Given this list of marker genes ATP1A2, TREX1, GAL, SCN1A, PI4KA, NHLRC1 (NHL repeat containing E3 ubiquitin protein ligase 1), LGI1 (NCBI Gene Id 9211), SRPX2, CACNA1A, NPRL2, KCNA1, EPM2A, MICAL1, PDE2A, DEPDC5, PCDH19 (protocadherin 19), RELN, PRRT2, ADGRG1, NPRL3, CNTN2, SCN8A, here is a description of the gene set: Epileptic aura Human Gene Set: HP_EPILEPTIC_AURA studied in species Homo sapiens An epileptic aura is a purely subjective clinical manifestation of an epileptic seizure. If an epileptic aura is not followed by loss of awareness or propagation to a bilateral tonic-clonic seizure then it is a type of focal aware non-motor seizure.